Given this list of marker genes Tgfb1, Gas1, Egr2, Foxp1, Fgf7, Col6a2, Zeb2, here is a description of the gene set: Somatic cells can be reprogrammed to a pluripotent state through the ectopic expression of defined transcription factors. Understanding the mechanism and kinetics of this transformation may shed light on the nature of developmental potency and suggest strategies with improved efficiency or safety. Here we report an integrative genomic analysis of reprogramming of mouse fibroblasts and B lymphocytes. Lineage-committed cells show a complex response to the ectopic expression involving induction of genes downstream of individual reprogramming factors. Fully reprogrammed cells show gene expression and epigenetic states that are highly similar to embryonic stem cells. In contrast, stable partially reprogrammed cell lines show reactivation of a distinctive subset of stem-cell-related genes, incomplete repression of lineage-specifying transcription factors, and DNA hypermethylation at pluripotency-related loci. These observations suggest that some cells may become trapped in partially reprogrammed states owing to incomplete repression of transcription factors, and that DNA de-methylation is an inefficient step in the transition to pluripotency. We demonstrate that RNA inhibition of transcription factors can facilitate reprogramming, and that treatment with DNA methyltransferase inhibitors can improve the overall efficiency of the reprogramming process. studied in species Mus musculus from publication Mikkelsen TS, Hanna J, Zhang X, Ku M, Wernig M, Schorderet P, Bernstein BE, Jaenisch R, Lander ES, Meissner A (PMID 18509334) Genes down-regulated in partially reprogrammed and pluripotent cell populations (induced, iPS; and embryonic stem cells, ES) compared to parental lineage-commited cell lines. Mouse Gene Set: MIKKELSEN_DEDIFFERENTIATED_STATE_DN